Given this list of marker genes LOXL3, LOXL4, LOX, LOXL2, LOXL1, here is a description of the gene set: Catalysis of the reaction: peptidyl-L-lysyl-peptide + H2O + O2 = peptidyl-allysyl-peptide + NH3 + hydrogen peroxide. species: Homo sapiens Human Gene Set: GOMF_PROTEIN_LYSINE_6_OXIDASE_ACTIVITY